Given this list of marker genes WNT7B, ENG, WNT7A, RTN4, CTNNB1, here is a description of the gene set: Human Gene Set: GOBP_CENTRAL_NERVOUS_SYSTEM_VASCULOGENESIS studied in species Homo sapiens The differentiation of endothelial cells from progenitor cells during blood vessel development, and the de novo formation of blood vessels and tubes in the central nervous system. The capillary endothelial cells in the brain are specialized to form the blood-brain barrier.